The following is a description of a gene set: Any process that modulates the frequency, rate or extent of signaling pathways initiated by the cross-linking of an antigen receptor on a T cell. Mouse Gene Set: GOBP_REGULATION_OF_T_CELL_RECEPTOR_SIGNALING_PATHWAY studied in species Mus musculus, and this is the list of marker genes: Cd81, Lgals3, Bcl10, Ptpn22, Ptprj, Pvrig, Usp12, Dusp22, Elf1, Dusp3, Nectin2, Itpripl1, Dgkz, Ikbkg, Kcnn4, Ptprc, Cd226, Cd160, Rps3, Ptpn2, Ezr, Rela, Lipa, Lck, Tespa1 (thymocyte expressed, positive selection associated 1), Lilrb4b, Btrc, Trat1, Cyld, Ada, Ceacam1, Prnp, Ubash3a, Ptpn6, Pawr, Thy1, Malt1, Cblb, Usp9x, Phpt1, Prkd2, Btnl2, Lilrb4a, Laptm5, Rab29 (NCBI Gene Id 226422), Sh2d1a, Sla2, Usp46, Ubr2, Ccr7, Nck1, Rc3h1, Cd300a, Card11, Btn2a2